Given this list of marker genes PPM1F, GDF2, SUPT7L, ATP6V0A1, CTDSPL, PRKD2, ANKRD10, NSUN5P1, GRAMD4, ARL3, ACVR2B, KLHDC2, ZNF586, HDAC3, MAST3, STAT5B, RPA1, CHAF1B, HLTF, MSH2, STRADA, RFC5, NDUFA2, BDH1, MPPED2, JADE1, EIPR1, PASK, ASXL2, SNAPC3, ASB1, CROCCP2 (CROCC pseudogene 2), PCBP4, KHK, ZMAT3, SLC26A6 (solute carrier family 26 member 6), S100B, CDK5, PARP2, POLR2H, WDFY3, PPM1H, SIVA1, TRPV4, OLFML2B (NCBI Gene Id 25903), LRIG1, CBY1, POLR3E, FHIP2B, MTSS1, FRMPD1, TTC3, GMCL1, PCNT, ARHGAP26, RASA1, DHRS11, MRTFB, MCM6, COQ8A, RMND5A, HILPDA, ABCC5, PIK3R4, NDUFA8, ADRA1D, TAS2R1, IFNGR1, GNLY, KATNB1, NT5DC2 (5'-nucleotidase domain containing 2), SAC3D1, MIEF1, RNFT2, ZNF74, RWDD2A, FAM216A, MMD, MAP4K1, SNRNP25, RBM4B, PLXND1, CNNM3, LDB3, HMBS, WDR37, ECT2 (epithelial cell transforming 2), TMEM223, TRMT61B, MAOA, DGKA, C2CD3, CDH6, SLC25A42, SLC7A8, FYCO1, USP39, HOMER3, UNC119B, CHD4, NFU1, STK11, AVPR2, TRIAP1, CYTIP, PRPF8, TPST2, MAP3K7, RCN2, PAGR1, MICAL2, NUAK1, TRIM8, PPM1D, RNF220, RFC4, GIPC2 (GIPC PDZ domain containing family member 2), COX11, ASB13, PCMTD2, ATP6V0E2, SEL1L, ESM1, NINJ2, TNFAIP1, SEPHS1, CRLF2, FGFBP1, RWDD2B, GOLGA8A, NFS1, GABRE, ATMIN (ATM interactor), LRRC8D, FAM193B, PTPN22, PHTF1, JPT1 (Jupiter microtubule associated homolog 1), SHQ1, USP46, SLC25A16, GTF3C2, RASGRP3, SYNRG, CACYBP, KCNMA1, GALNT7, ZER1, MARF1, KANK2, RHOBTB2, DIP2C, SLITRK3, SLC5A3, DYNC2LI1, MTUS1, LIMS1, SSBP3, VPS72, RBM23, PARL, SV2C, ADAMTS3, CUTC, SYNE1, LAGE3, MDM1, CDK2AP2, CTCF, MCM7, CDKN2A-AS1, STXBP1, NCKIPSD, TNK1, HMGCL, PCDHA5, NPY6R, TMEM14B, EZH1, CCDC93, MCM5, CCNG2, TMPO, JTB, TBC1D16, OGG1, DAG1, SPSB3, MRPL19, CREB3L2, GRK6, NAA16, UBE4B, PLA2G12A (phospholipase A2 group XIIA), PPP2R5D, TBC1D13 (NCBI Gene Id 54662), LUC7L2, LAMC1, FBXO21, MRS2, here is a description of the gene set: Microglial cells are resident macrophages in the central nervous system (CNS) and play a pivotal role in the innate and adaptive immune responses against microbial infections. The immune functions of microglia are regulated by a milieu of cytokines including interferon (IFN)-gamma. We here performed a series of experiments to acertain the transcriptional profile of human fetal microglial cells at 1, 6, and 24 h after IFN-gamma treatment. Primary human microglial cells were either untreated or treated with 200u/ml IFN-gamma. Affymetrix U133A chips were utilized. Four different tissue samples (B18, O, W, and Y20) were analyzed at the three time points. Genes up-regulated in comparison of control microglia cells versus those 6 h after stimulation with IFNG. from publication Rock RB, Hu S, Deshpande A, Munir S, May BJ, Baker CA, Peterson PK, Kapur V (PMID 16163375) Human Gene Set: GSE1432_CTRL_VS_IFNG_6H_MICROGLIA_UP species: Homo sapiens